Given this list of marker genes Yy1, Prkdc, Cyren, Tcf3, Polb, Ezh2, Xrcc4, Foxp1 (NCBI Gene Id 73231), Lig4 (NCBI Gene Id 319583), Nhej1, here is a description of the gene set: studied in species Mus musculus The process in which immunoglobulin gene segments are recombined within a single locus utilizing the conserved heptamer and nonomer recombination signal sequences (RSS). For immunoglobulin heavy chains V, D, and J gene segments are joined, and for immunoglobulin light chains V and J gene segments are joined. Mouse Gene Set: GOBP_IMMUNOGLOBULIN_V_D_J_RECOMBINATION